The following is a description of a gene set: studied in species Mus musculus Mouse Gene Set: MIR_669K_5P Genes predicted to be targets of miRBase v22 microRNA mmu_miR_669k_5p in miRDB v6.0 with MirTarget v4 prediction scores > 80 (high confidence targets). from publication Chen Y, Wang X (PMID 31504780), and this is the list of marker genes: Mdga2, Cd200r4, Sema5a, Hectd1, Kat6a, Tm2d2, Lyrm7, Kcnj16, Cpeb4, Nlgn3, Mcf2, Ank1, Nin, Bmp7, Elmod1, Fastkd2, Fjx1, Mmrn1, Ankrd44, Spx, Sorbs2, Htr5a, Cetn3, Zfp882, Prrg4, Amotl1, Pkn2, Matr3, Cnpy4, Spock1, Zbtb37, Pde3a, Ppm1h, Mro, Gpbp1l1 (GC-rich promoter binding protein 1-like 1), Adamts5, Scai, Zfp157, Edem1, Sall1, Taf3, Kif20a, Rc3h2, Kcnn2, Ap1b1, Bean1, Atl1, Fam229a, Fbxl5, Nectin1, Kcnb1, Nlrp1a, Triobp, Nsun6, Zfp641, Ggps1, Chst2, Rnf11, Rgs4, Copg1, Commd2 (COMM domain containing 2), Onecut3, Kcnh5, Elfn1 (leucine rich repeat and fibronectin type III, extracellular 1), Wdr44, Neurod6 (neurogenic differentiation 6), Pou4f1, Slc25a13, Bnc2, Nim1k, Fam169b, Cbx7, Gdf6, Treml4, Ostm1, Enpp6, Mmp16, Slc20a1, Irf1, St18, Kif5a, Tnrc6c, Fchsd2, Arhgef9, Stard3nl, Pogz, Iglon5, Hivep2, Ube2k, Ssbp2, Ankrd49, Nkain2, Rorb, Snn, Cyria, Tubal3, Usp25, Ythdf3, Gcnt4, Ppp1r10, Ankmy2, Rspo1, Cntn1, Gdap1, Slc6a19, Ywhab, Spire1, Cmtm4, Crh, Cftr, Pappa, Stx1b, Ufsp2, Tsc22d2, Pdik1l, Fam216b, Tomm70a, Marchf2, Nup58, Kcnj6, Dnah17, Ada, Pycard, Capn6, Lamp1, Nr6a1, Kras, BC005537, Ddhd2, Fbxo28, Grik2, Cpeb2, Neurl4, Cnr1, Msantd4, Thrb, Zc3h12d, Ano4, Chst11, Vapb, Ebf2, Akap9 (NCBI Gene Id 97235), Tmem170b, Hoxa9, Mgat4c (MGAT4 family, member C), Elf2, Cacna2d1, Prxl2a, Skint10, Qser1